Given this list of marker genes Ripor2, Cd200r1, Apod, Cd200, Il27ra, Cd69, Lrch1, here is a description of the gene set: Any process that stops, prevents or reduces the frequency, rate or extent of T cell migration. Mouse Gene Set: GOBP_NEGATIVE_REGULATION_OF_T_CELL_MIGRATION studied in species Mus musculus